Given this list of marker genes Ap2b1, Nsf, Prkca, Grip1, Ap2m1, Prkcg, Ap2s1, Ap2a1, here is a description of the gene set: part of: Trafficking of AMPA receptors electronically inferred by orthology from the curated human pathway studied in species Mus musculus Reactome Pathway: Trafficking of GluR2-containing AMPA receptors This event has been computationally inferred from an event that has been demonstrated in another species.<p>The inference is based on the homology mapping from PANTHER. Briefly, reactions for which all involved PhysicalEntities (in input, output and catalyst) have a mapped orthologue/paralogue (for complexes at least 75% of components must have a mapping) are inferred to the other species.